Given this list of marker genes Xdh, Uox, Urah, Urad, Pnp, here is a description of the gene set: Mouse Gene Set: GOBP_DEOXYINOSINE_METABOLIC_PROCESS studied in species Mus musculus The chemical reactions and pathways involving deoxyinosine, hypoxanthine deoxyriboside.